The following is a description of a gene set: electronically inferred by orthology from the curated human pathway species: Mus musculus This event has been computationally inferred from an event that has been demonstrated in another species.<p>The inference is based on the homology mapping from PANTHER. Briefly, reactions for which all involved PhysicalEntities (in input, output and catalyst) have a mapped orthologue/paralogue (for complexes at least 75% of components must have a mapping) are inferred to the other species. part of: Chondroitin sulfate/dermatan sulfate metabolism Reactome Pathway: CS-GAG biosynthesis, and this is the list of marker genes: Chst15, Dcn, Bgn, Csgalnact1, Csgalnact2, Chsy3, Chst9, Cspg5, Chst13 (NCBI Gene Id 71797), Chsy1, Chst12, Ust